Given this list of marker genes APOBEC3G, POU2F2, ITGB7, CACNG4, PTTG1 (PTTG1 regulator of sister chromatid separation, securin), FLT3LG, CD74, LIMD2, TRAPPC13, TNFAIP2 (TNF alpha induced protein 2), ZNF292, NYAP2, MX1, CD200, CPVL, ABCB1, CASP1, HVCN1, LCK, P2RY10, APOLD1, IRF1 (interferon regulatory factor 1), IL1R1, SAMSN1, ISG20, FASTKD1, CD48, MED12L, SPARC, CNRIP1, EML4, ABTB1, CYFIP2, PASK, ZP3, KCNQ5, ADAM8, PTCRA, DDA1, CYP27A1, ARMCX6, CPQ, IGKC, CXCR6, DBP, LILRB1, SYNE2, PIK3C2B, CXCR4, BANK1, CD19, RRAGD, UNC5D, IL16, TTLL2, PRKCQ, HLA-DMB, IRAG2, MTHFD2, IL15, KLHL14, TRIB2, KIAA0753, DNAJC14, AXIN1, TPTE, SLC7A7, CCDC186, FADS1, STAG3, CXCL13, PIM2 (NCBI Gene Id 11040), BLMH (bleomycin hydrolase, NCBI Gene Id 642), MYCBP2, PTPRC, USP30, HS3ST1, APOL3, IL10RA (NCBI Gene Id 3587), KLF12, CD79B, TXLNGY (taxilin gamma Y-linked (pseudogene)), IGHG3, KANK1, MT2A (NCBI Gene Id 4502), LPAR6, SP110, ARAP2, HLA-DMA, TXNIP, SPIB, FOXP1, USP34, THUMPD1, GMCL1, CPSF7, HLA-DRB3, DGKA, CR2, POLR3B, IRF4, ITGA1, ZNF322, BBS2, TRIM22, IL7, VCAM1, STAT2, IGLL1, CCN3, ACP2, NEK11, PLCL2, TCN1, RNF31 (NCBI Gene Id 80191), NME3, CARD16, MYOF, SELP, UTY, NLRC5, ALOX5, SPINT2, PNPT1 (NCBI Gene Id 87178), S1PR1, PRKCH, PTPRCAP, SELL, CD59, ZNF436, RNPC3, IRF7, PDE4DIP, GZMA, SAMHD1, FYN, XRN1, KIF27, KCNA3, DNMT3A, STAT4, HLA-G, HLA-A, here is a description of the gene set: Human Gene Set: MODULE_119 species: Homo sapiens Genes in the cancer module 119.